The following is a description of a gene set: To investigate the roles of Klf3 in B lymphopoiesis, CD19+ B cells were sorted from the spleens of WT and Klf3 KO mice (Molecular and Cellular Biology (2008); 28:3967–3978). Following RNA extraction, gene expression was compared in WT and Klf3 KO CD19+splenic B cells using Affymetrix microarrays. from publication Vu TT, Gatto D, Turner V, Funnell AP, Mak KS, Norton LJ, Kaplan W, Cowley MJ, Agenès F, Kirberg J, Brink R, Pearson RC, Crossley M (PMID 22003205) species: Homo sapiens Genes down-regulated in splenic B lymphocytes: wildtype versus KLF3 knockout. Human Gene Set: GSE31622_WT_VS_KLF3_KO_BCELL_DN, and this is the list of marker genes: EIPR1, GRINA, TUT1, EGLN3, NR3C1, PRSS16, PLOD3, STX11, CACNA1G, GFI1B, LCMT2, MS4A13, EHMT2, PRKX, MED11, LINC01973, GPR35, TMEM176B, IFITM2, ITGA9, TPP2, PIK3R5, RAB20, ITPRIPL2, GZMA, SLC17A6, DENND4B, GGPS1, RBM42, E2F4, CERK, RNF135, KCNK6, MUL1, PEDS1, GPR174, CCL4, NEPRO, ZNFX1, NHSL2, SORCS2, TNFRSF9, CNPY1, TMEM51, ZBTB5, FEZ2, SMARCD2, TTC39C, TMCO2, FAM47E, RUNDC1, MCMBP, PWP2, UBE2F, GZMK, CD86, KHDRBS1, FHIP2A, PFKFB3, KLF3, CD72, DAP, OCEL1, HDHD3, SUN3, BMX, MVP, DCXR, NOS2, POU2F2, TRAIP, IL20RA, PHF21B, RANBP3L, RBM14, PTTG1, CRABP2, MZT1, UTP23, SPN, STMN4, SRSF10, CA9, CEP295, MAFG, PLA2G10, TNFSF11, CD247 (NCBI Gene Id 919), FES, GIT1, PUM1, GAPVD1, MFF, NICOL1, GAD2, USP10, PRSS8, DENND1C, AIDA, UMPS, NFKB2, ADCY8, AXL, TRIB1, SH3KBP1, GART, FOXP3, CCDC88B, PTPN1, PPM1H (protein phosphatase, Mg2+/Mn2+ dependent 1H), MCM10, GRM5, ZNF175, TAC1, EFCAB3, FMNL1, FBXL19, MARCHF2, WDR81, TMA16, GSDMD, BCL2L13, SEZ6L2, CGAS (cyclic GMP-AMP synthase), MCL1, MYD88, PRR14L, RAB3IL1, DDX24, CCDC107, POGK, UTP25, YWHAB, DCSTAMP, TNFSF8, PYGO2, ATXN1L, NFATC3, NOLC1, KIF3B, RIN3, SLC16A6, PDZD8, RUFY2, SELE, BET1L (Bet1 golgi vesicular membrane trafficking protein like), KRT16, NOP58, CD4, CRLF3, ADD1, PLBD1, TIMELESS, MYO19, NRROS, GALNT7, SLC7A11, GPR101, NRAS, LRP8, KRTAP13-2, STARD7, STIM2, STEAP1, ATF7IP, PLXNB3, FAM53B, PTGER1, MAP1S, TLE3, E2F2, NAP1L2, QNG1, HTT, SMARCA4, SHISA3, SPATA1, SOCS3, TMEM185A, DHX16, SPPL2A, CMTM6, RNF19B, TSPAN32, TULP4, BRWD3, OLFM2, MGLL, OSM, SEMA4B, TSR1, AIRE, NAGPA, METRNL, ARPC5L (NCBI Gene Id 81873), WDR12, HGF, FBXL18, SLAMF9, SIPA1